Given this list of marker genes IL6, DEFB124, TNFRSF11A, HMGB1, CX3CR1 (NCBI Gene Id 2836), CCL1, PDGFB, CCL2, CCR1, S100A14, DEFB104B, DEFB131A, CREB3, CCL3, SLAMF8, CCN3, MOSPD2, PF4, MSMP, TNFSF11, CCR2, CCL23, CXCL17, CALCA, PTPRO, RPS19, NINJ1, DEFB104A (NCBI Gene Id 653669), MICOS10-NBL1, IL6R, ANXA1, APP, S100A12, LGMN, LGALS3, FLT1, NBL1, PLA2G7, S100A7, FPR2, ANO6, DUSP1, SLIT2, TNFSF18, SERPINE1, CCL26, CCL5, CTSG, CCL7, CXCL12, GREM1, CXCL10, LYN, FOLR2, AIF1, here is a description of the gene set: Human Gene Set: GOBP_MONOCYTE_CHEMOTAXIS studied in species Homo sapiens The movement of a monocyte in response to an external stimulus.